Given this list of marker genes Trbc1, Trbv19, Cd3e, Trbc2, Ptpn6, Trac, Igkc, Cd3d, Cd3g, Cd247, Trav18, here is a description of the gene set: A T cell receptor complex in which the TCR heterodimer comprises alpha and beta chains, associated with the CD3 complex; recognizes a complex consisting of an antigen-derived peptide bound to a class I or class II MHC protein. Mouse Gene Set: GOCC_ALPHA_BETA_T_CELL_RECEPTOR_COMPLEX species: Mus musculus